The following is a description of a gene set: Genes predicted to be targets of miRBase v22 microRNA mmu_miR_7069_5p in miRDB v6.0 with MirTarget v4 prediction scores > 80 (high confidence targets). species: Mus musculus Mouse Gene Set: MIR_7069_5P from publication Chen Y, Wang X (PMID 31504780), and this is the list of marker genes: Ppp1r13l, Nrg3 (NCBI Gene Id 18183), Pin1rt1, Nectin1, Ndrg1, Rusc1, Col1a1, Epg5, Cmah, Arhgap27, Cstf2, Lrrc4b, Necap2, Trim14 (NCBI Gene Id 74735), Fam222b, Serpinc1, Yipf4, Kifc2, Mup21, Gimap3, Ttc28, Dennd2a, Sumf1, Dnmbp, Ttyh3, Scmh1, Rasgef1a, Ube3a, Tmem26, Zfp710, Cilk1, Crhr1, Col5a3, Tsr2, Mybpc1, Ankrd13b, Slc6a2, Ypel5, Lamp5, Actb, Mapk8ip2, Tmem185a, Vamp2, Cbx6, Nfix, Klra17, Flrt1, Tsga8, Cplx2 (NCBI Gene Id 12890), Cdkn1b, Nelfe, Sec61a2, Nol3, Nr6a1, Sit1, Nat8l, AU040320, Zfp827, Grik2, Prdm8, Iqsec2, Asic1 (acid-sensing ion channel 1), Dnase1l3, Stum, Ccdc167, Opcml, Dlgap1, Scn2b, Gatad2b, Ormdl3, Hspa12b, Kcnb1, Prkca, Eva1b, Usp21, Spred3, Ncdn